Given this list of marker genes Tead4, Tead2, Yap1, here is a description of the gene set: electronically inferred by orthology from the curated human pathway studied in species Mus musculus Reactome Pathway: RUNX3 regulates YAP1-mediated transcription part of: Transcriptional regulation by RUNX3 This event has been computationally inferred from an event that has been demonstrated in another species.<p>The inference is based on the homology mapping from PANTHER. Briefly, reactions for which all involved PhysicalEntities (in input, output and catalyst) have a mapped orthologue/paralogue (for complexes at least 75% of components must have a mapping) are inferred to the other species.